Given this list of marker genes Ppp4c, Polr2f, H2ac12, H2bc12 (NCBI Gene Id 319184), Rchy1, Rfc3, Fignl1, Xab2, Usp45, Ercc4, Pole, Polk, Mus81, Brca1, Gtf2h2, H2bc27, Rps27a, Mdc1, H2ac22, Polr2i, Fancg, Acd, Ercc2, Smarca5, Babam1, H2az2, Poli, Kat5, Vcp, Ufd1, H4c4, H4c6, Hus1, Xrcc3 (X-ray repair complementing defective repair in Chinese hamster cells 3), Msh6, Slx4, Pclaf, Fance, Dtl, Pold1, Polr2e, Ogg1, Xrcc6, Usp1 (ubiquitin specific peptidase 1), Prkdc, Xrcc1, H2ac6, H4c1, Bard1, Faap20, Tdg, Pms2, H2ac11, Tfpt, Fan1, Terf1, Msh2, Rbbp8, Rnf168, Tdp2, Apbb1, H2bc7, Rnf111, Cenps, Apex1, Brcc3, Fancc, Mpg, Pcna, Polr2l, H2ac20, Ccnh, Fto, H2ac1, Gen1, Lig1, Yy1, Msh3, H2bc13, H2bc22, Pold4, Pole2 (NCBI Gene Id 18974), Eya3 (NCBI Gene Id 14050), H2bc3, Rad1, Slx1b, H2ac8, Ppp4r2, Rnf4, Ercc6, Mbd4, Wdr48, Mutyh, Terf2, Prpf19, H4c14, H2ac19, Ino80c, Cenpx (NCBI Gene Id 20892), Cul4b, Poln, Neil2, Dna2 (NCBI Gene Id 327762), Eya1, Ino80b, Uvssa, Polr2b, Rfc1, Polr2c, Gtf2h4, Polh, Cops6, H2ac23, Xpc, Nthl1, Fancb, Zfp830, Usp43, Ercc1 (NCBI Gene Id 13870), H2ax, Rad52 (RAD52 homolog, DNA repair protein), Nhej1, Rad51b (RAD51 paralog B), H4c18, Blm, H2ac13, Ddb1, Nfrkb, Polr2k, Mad2l2, Alkbh5, Rad51ap1, H4c12, Mre11a, Faap100, Polr2a, H2ac15, Xpa, Tcea1, Cul4a, H2ac10, Pias4, Rad51c, Ube2n, H2bc1, H4c17, Adprs, H4c8, Sumo1, Neil1, Chd1l, H4c2, Trp53bp1, H4c9, Rpa1, Brca2, Polm, Wrn, Ercc3, Lig4, H2bc11, Rad9a, Mapk8, Ppp5c, H2ac24, Firrm, H4c3, H2ac7, Rev3l, Sprtn, H2bc8, Ccna1, Uba7, Paxip1, H2ac4, H2bc15, Chek2, Ubb, Trp53, Nbn, H4c11, Polq, Top3a, Palb2, Pold2, H2bc9, here is a description of the gene set: This event has been computationally inferred from an event that has been demonstrated in another species.<p>The inference is based on the homology mapping from PANTHER. Briefly, reactions for which all involved PhysicalEntities (in input, output and catalyst) have a mapped orthologue/paralogue (for complexes at least 75% of components must have a mapping) are inferred to the other species. species: Mus musculus Reactome Pathway: DNA Repair electronically inferred by orthology from the curated human pathway